Given this list of marker genes Hspa1a, Hspa2, Dnajb1, Hsbp1, Hsf1, Hsp90ab1, Hspa8, Hspa1l, Hsp90aa1, Hspa1b, Ptges3, Ep300, Fkbp4, here is a description of the gene set: species: Mus musculus Attenuation phase Mouse Gene Set: REACTOME_ATTENUATION_PHASE